The following is a description of a gene set: Any process that modulates the frequency, rate or extent of protein autoubiquitination. studied in species Homo sapiens Human Gene Set: GOBP_REGULATION_OF_PROTEIN_AUTOUBIQUITINATION, and this is the list of marker genes: LRRK2, TAF1, SASH1, MTA1, RBX1, MARCHF7